The following is a description of a gene set: Mouse Gene Set: GOBP_REGULATION_OF_STEROID_BIOSYNTHETIC_PROCESS studied in species Mus musculus Any process that modulates the frequency, rate or extent of the chemical reactions and pathways resulting in the formation of steroids, compounds with a 1,2,cyclopentanoperhydrophenanthrene nucleus., and this is the list of marker genes: Hsd3b4, Nr3c1, Dhh, Tnf (tumor necrosis factor), Adora2b, Igfbp7, Fshb, Fgfr4, Mapk1, Snai2, Nr0b1 (NCBI Gene Id 11614), Nfkb1, Fgf15, Insig1, Tspo, Stard4, Aqp8, Sod1, Prox1, Il1a, Fgf1, Bglap, Bmp2, Paqr3, Snai1, Ifng, Ces1c, Ces1b, Igf2, Dgkq, Hsd3b8, Ddx20, Abcg4, Hsd3b5, Gh, Apob, Pde8b, Lep, Apoe, Igf1r, Ces1f, Star, Cyp17a1, Erlin2, Gprc6a, Akr1c18, 3110082I17Rik, Pex2, Asah1, Gpr146, Hsd3b9, Bmp5, Fdps, Npy1r, Dkk3, Rest, Dhcr7, Ces1h, Hrh1, Por, Sirt1, Dkkl1, Srebf2, Nr5a2, Gfi1, Ppargc1a, Cga, Dab2, Ces1a, Egr1, Sf1, Atp1a1, Ces1e, Insig2, Scap, Nr1d1, Ces1g, Ggcx, Sec14l2, Ces1d, Gnai1, Cyp27b1, Creb1, Bglap2, Abcg1, Lpcat3, Clcn2, Scp2, Bmp6, Malrd1, Armc5, Lhcgr, Idi2, Prkg1, Cmtm2a, H6pd (hexose-6-phosphate dehydrogenase (glucose 1-dehydrogenase)), Erlin1, Prkaca, Cyp7a1, Wnt4, Qki, Igf1, Mbtps2, Srebf1 (sterol regulatory element binding transcription factor 1)